Given this list of marker genes MINPP1, here is a description of the gene set: part of: Inositol phosphate metabolism studied in species Homo sapiens In the endoplasmic reticulum (ER) lumen, inositol phosphates IP4, IP5, and IP6 are dephosphorylated by multiple inositol polyphosphate phosphatase 1 (MINPP1). Reactome Pathway: Synthesis of IPs in the ER lumen